The following is a description of a gene set: part of: ATP-dependent chromatin remodelers studied in species Mus musculus This event has been computationally inferred from an event that has been demonstrated in another species.<p>The inference is based on the homology mapping from PANTHER. Briefly, reactions for which all involved PhysicalEntities (in input, output and catalyst) have a mapped orthologue/paralogue (for complexes at least 75% of components must have a mapping) are inferred to the other species. Reactome Pathway: SWI/SNF chromatin remodelers electronically inferred by orthology from the curated human pathway, and this is the list of marker genes: Smarcc1, Smarcb1, Bicral, Ss18l1, Arid1a, Dpf1, Smarcc2, Bcl7a, Ss18, Smarca4, Phf10, Smarcd2, Smarcd1, Bcl7b, Smarca2